Given this list of marker genes SLN, SEMG1, PPP3R1, SLC30A1, PPP3CC, MIR34A, PPP3CB, EPPIN, MIR200C, PPP3R2, TRIM27, SPINK1, MIR208B, HES1, PLN, PPP3CA, MIR208A, here is a description of the gene set: Human Gene Set: GOBP_NEGATIVE_REGULATION_OF_CALCIUM_ION_IMPORT studied in species Homo sapiens Any process that decreases the rate, frequency, or extent of the directed movement of calcium ions into a cell or organelle.